Given this list of marker genes LRRTM2, SDCBP, ANKRD13D, MTMR2, WDR54, ATXN2, PCSK9, LRRTM1, UBQLN2, MIR199A1, ANKRD13A, LRPAP1, NECAB2, ANKRD13B (ankyrin repeat domain 13B), RIN3, ANXA2, DLG4, here is a description of the gene set: Any process that stops, prevents, or reduces the frequency, rate or extent of receptor internalization. Human Gene Set: GOBP_NEGATIVE_REGULATION_OF_RECEPTOR_INTERNALIZATION studied in species Homo sapiens